Given this list of marker genes Hras, Map2k7, Mapk3, Ms4a2, Igll1, Grb2, Fos, Lcp2, Mapk9, Vav1, Syk, Fcer1a, Jun, Plcg2, Shc1, Mapk8, Grap2, Map2k4, Lat, here is a description of the gene set: This event has been computationally inferred from an event that has been demonstrated in another species.<p>The inference is based on the homology mapping from PANTHER. Briefly, reactions for which all involved PhysicalEntities (in input, output and catalyst) have a mapped orthologue/paralogue (for complexes at least 75% of components must have a mapping) are inferred to the other species. part of: Fc epsilon receptor (FCERI) signaling Reactome Pathway: FCERI mediated MAPK activation species: Mus musculus electronically inferred by orthology from the curated human pathway